The following is a description of a gene set: A large, elongated, rod-shaped secretory granule characteristic of vascular endothelial cells that contain a number of structurally and functionally distinct proteins, of which the best characterized are von Willebrand factor (VWF) and P-selectin. Weibel-Palade bodies are formed from the trans-Golgi network in a process that depends on VWF, which is densely packed in a highly organized manner, and on coat proteins that remain associated with the granules. Upon cell stimulation, regulated exocytosis releases the contained proteins to the cell surface, where they act in the recruitment of platelets and leukocytes and in inflammatory and vasoactive responses. Human Gene Set: GOCC_WEIBEL_PALADE_BODY species: Homo sapiens, and this is the list of marker genes: EDN1 (NCBI Gene Id 1906), VWF, APOLD1, UNC13D (unc-13 homolog D), RAB27A, CRACR2A, ECE1